Given this list of marker genes CYSLTR2, F2R, GPR132, GPR183, CCL16, CXCL1, OPRK1, CHRM3, LHCGR, CCR6, INSL3, PLPPR3, RRH, GPBAR1, AVPR1B, OPN4, GAL, NPSR1, PPBP, AGT, XCL1 (NCBI Gene Id 92337), FSHR, F2RL2, GHSR, HTR1F, NPB, OPRL1, CCL22, MC2R, CXCL12, HTR2A, OXER1, ACKR1, OXT, CXCL2, HCRT, PPY, NPY2R, NLN, PF4, CXCL3, CCL4, S1PR5, HCAR1, TSHB, HTR1D, CXCR4 (NCBI Gene Id 93405), TAC3, CGA, CCL7, LPAR4, FFAR1, GRPR, S1PR4, GPER1, HEBP1, APLNR, ADORA3, HTR4, CXCL5, CORT, NMU, RXFP1, SSTR1, CCL3, TAAR1, MCHR2, FFAR2, MLNR, AGTR1, HRH1, KNG1, PRLHR, TAAR9, TAAR8 (NCBI Gene Id 83551), HCAR2, UTS2, CCR2, CCL11, GALR1, GPR65, CXCL11, FSHB, GPR37, BDKRB1, FPR3, ECE1, NMUR2, GPR143, CXCL9, ECE2, MC5R, CCR5 (NCBI Gene Id 727797), ADRA2A, TACR1, CHRM1, C5, ADRB2, ADORA2A, CYSLTR1, HTR1E, TAAR6, F2RL3, LTB4R, PTGER2, SSTR2, DRD2, HTR6, LPAR6, POMC, PTAFR, GHRL, GPR39, MC4R, TRHR, P2RY14, CCL20 (C-C motif chemokine ligand 20), OXTR, CX3CR1, ACKR2, P2RY1, NPFFR1, CCL21, PROK2, CXCL10, PRLH, AVP, CHRM4, SSTR3, AVPR1A, S1PR3, NMBR, ANXA1, OPN3, PTGFR, GPR68 (G protein-coupled receptor 68), TBXA2R, HTR1B, PSAP, FFAR3, CCL13, PROK1, PLPPR2, PTGER1 (prostaglandin E receptor 1), P2RY2, NPY, LHB, GPR37L1, ADRB3, C3 (NCBI Gene Id 12266), CCL27, BDKRB2, NPBWR2, PNOC, HRH4, ADRA2C, GPR35, QRFPR, CHRM5, PROKR1, NMB, CXCR6, OPN1SW, CNR1, XK, GPHB5, CCL1, PROKR2, MC3R, QRFP, HTR5A, UTS2R, MTNR1B, TACR3, DRD3, FPR2, LPAR3 (NCBI Gene Id 23566), CCR7, TAAR5, PTGDR2, MTNR1A, RLN3, RXFP4, P2RY4, C5AR1, F2RL1, MCHR1, XCL2, AVPR2, GPR55, ADORA2B, CMKLR1, HRH3 (histamine receptor H3), TAAR2, TAC1, ACKR3 (NCBI Gene Id 57007), CCR9, XCR1, RXFP3, ADRA2B, CCRL2, CXCR3, ACKR4, CCR10, CHRM2, PTGER4, OPN1MW, P2RY11, CCKBR, EDNRB, NTS, MLN (NCBI Gene Id 4295), EDN1 (endothelin 1), KEL, PTGIR, LPAR2, GPR17, SSTR5, S1PR1, EDN3, P2RY10, CCL23, P2RY13, UTS2B, RXFP2, NPFFR2, CCKAR, CX3CL1, GPR31, SST, CCL2, HRH2, HTR1A, MC1R, ADORA1, LPAR5, CCK, KISS1, CCR1 (NCBI Gene Id 1230), RHO, ADRA1B, P2RY6, PENK, NPBWR1, GPR18, LTB4R2, CCR4, PDYN, CXCR1, CXCL8, EDN2, OPRD1, PLPPR4, CNR2, KISS1R, HTR7, CCL3L3, NPS, DRD4, NMUR1, F2, TSHR, PMCH, C3AR1, PLPPR1, INSL5, P2RY12, GPHA2, OPRM1, NMS, HCRTR2, CCR3, NPW, BRS3, FPR1, PTGER3, SUCNR1, TACR2, APP, OPN5, NTSR2, HTR2B, SAA1, C5AR2, CCR8, DRD1, CCL25, CCL17, RGR, HCAR3, EDNRA, CCL5, APLN, OPN1LW, GNRH1, HCRTR1, SSTR4, GALR2, NTSR1, NPFF, CXCR2, CXCR5, NPY4R, AGTR2, GNRHR, GALR3, TRH, CCL19, NPY1R, ADRA1D, CXCL16, GPR4, ADRA1A (adrenoceptor alpha 1A), FFAR4, PLPPR5, RLN2, DRD5, S1PR2, OXGR1, NPY5R, CXCL6, ADRB1, PYY, CXCL13, GRP, GNRH2, CCL28, PTGDR, HTR2C, LPAR1, here is a description of the gene set: Class A/1 (Rhodopsin-like receptors) species: Homo sapiens Human Gene Set: REACTOME_CLASS_A_1_RHODOPSIN_LIKE_RECEPTORS